The following is a description of a gene set: The process whose specific outcome is the progression of a lens fiber cell over time, from its formation to the mature structure. Cell development does not include the steps involved in committing a cell to a lens fiber cell fate. A lens fiber cell is any of the elongated, tightly packed cells that make up the bulk of the mature lens in a camera-type eye. species: Homo sapiens Human Gene Set: GOBP_LENS_FIBER_CELL_DEVELOPMENT, and this is the list of marker genes: WNT7A, WNT7B (Wnt family member 7B), CRYGB, EPHA2, PROX1, BFSP1, ATF4, VIM, BFSP2, CRYAA, ABI2, FRS2, WNT5B, TBC1D20, TMOD1